Given this list of marker genes RIMKLB, DUSP6, EIF5AL1, RHOJ, PHF1, OPRM1, ATXN7, TTC9C, CPM, GRIA4, DIP2A, ZNF248, TPP2, CEP350, TARBP2, RASA1, DLG2, ZC3H11A, ARL8A, KLF7, ASB4, HDX, PBX3, KPNA6, MED13L, LIN28B, C17orf49, ADSS2, PRRC2C, CNNM4, CTBP2, NOVA1, SMIM8, GPD1, NAT8L, NEDD4L, SHROOM3, ZNF276, BTN3A2, B4GALT4, EHHADH, MMP14, OTUD4, S100P, EYA3, FSD2 (fibronectin type III and SPRY domain containing 2), KCND1, POU2F1, EXOC5, MAX, MLKL, ACER2, ZEB1, RBMS1, FKTN, YTHDF1, OTUD3, DDOST, CSMD1, CCKBR, ANAPC13, AKAP13, MAPK1, SPRED2, SPRYD7, LYRM1, SFMBT1, ARL8B, ST13, SDR42E1, CREBZF, NAA40, ATP11A, BLOC1S6, ADAMTS5, SSH1, CHN2, AFF4, PARD6B, RFESD, MARK3, TFAP2B, TCEAL8, IRGQ, RGS16, LRP11, ATAT1, VAT1, CYP8B1, RUFY3, LCK (NCBI Gene Id 95387), TMEM105, SFT2D2, CEP135, ZNF689, GRIA2, MANEAL, ZFHX4, C2, MTMR4, MPEG1, CSNK1E, NID2, FAS, OCIAD2, ASTN2, ZNF3, RAB8B, SLC10A7, TUBB4A, GATM, ACTR8, HNRNPM, KLHL28, GPATCH2, WT1, QKI, TPTEP2-CSNK1E, IL10, SST, FRMD7, PTPRB, LEPROTL1, TNRC6C, SPRYD4, C17orf50 (NCBI Gene Id 146853), OSBPL11, here is a description of the gene set: Genes predicted to be targets of miRBase v22 microRNA hsa-miR-4257 in miRDB v6.0 with MirTarget v4 prediction scores > 80 (high confidence targets). Human Gene Set: MIR4257 from publication Chen Y, Wang X (PMID 31504780) species: Homo sapiens